Given this list of marker genes LMOD2, KHDC3L, DIAPH1, MIR21, SYNPO2L, ACTR3, MYO1F, TJP1, MICAL1, CCR7, CAPZA2, TMSB15A (NCBI Gene Id 11013), DIAPH2, C15orf62, PACSIN1 (protein kinase C and casein kinase substrate in neurons 1), ARAP1, SYNPO2, TSC1, CORO6, TACR1, FAT1 (FAT atypical cadherin 1), HIP1, ARPIN, JAK2, TMOD3, RAC1, ADD1, CDC42EP2, WIPF3, GSN, SPIRE1, RICTOR, TAGLN3, VASP, SH3D21, PHACTR1 (NCBI Gene Id 81705), CTTN, MYO7B, PALM2AKAP2, RND3, RHOA, DNM2, SPTBN2, SMAD3, CNN3, MICALL2, SHROOM4, TRPV4, KASH5, KBTBD13, WASHC3, FSCN1, S1PR1, HSP90B1, GAS2L2, ITGB1, PFN3, MYO7A, MYO5C, WASHC5, DBN1, TMSB10 (NCBI Gene Id 9168), ERMN, SYNPO, SPIRE2, RHPN2, SLC9A1, WASF2, CORO2B, ARRB1, ARHGEF10, MICAL3, SDC4, MYOC, ARPC1B, GHSR, INF2, MYO5B, MTSS1, WASHC4, PLS3, FCHSD1, TLE6, ENAH, NRAP, ARHGAP6, KANK2, CORO7, SPTBN5, RHPN1, POF1B, WASL, ARF6, LIMA1, PAK2 (p21 (RAC1) activated kinase 2), CFL1, CX3CL1, SORBS3, ITGB1BP1, IQGAP2, PPP1R9B, CYRIB, XIRP1, PROX1, BCAR1, PTK2B, ALOX15, GMFG, PRKCI, TESK1, CORO1A, CORO1B, ARHGEF10L, PXN, CAPG, PPM1E, MTPN, RAC2, SFRP1, BBS4, RAC3, CCN2, ASAP3, MYADM, MARCKSL1, ARPC3, RND2, SH3BP1, WASH3P, EPHA1 (EPH receptor A1), APOA1, MYO1G, GPR65, ROCK2, WNT4, VIL1, MYO15A, SHROOM2, SRF, RHOF, TMSB15B, NCKAP1L, PTGER4, GAS2, FHOD1, ADD2, NEDD9, DIAPH3, TMOD2, MYO1E, PIK3R1 (NCBI Gene Id 5295), MARCKS, CORO1C, ARHGEF2, FSCN3, TTC8, XIRP2, AIF1L, SORBS1, ARF1, TTN, CRYAA, PRKN, RHOBTB1, ESPN, SAMD14, HDAC6, CYFIP2, RNH1, ARFIP2, PPM1F, CARMIL1, AQP5-AS1, CCL11, CDC42EP5, NEB, CYRIA, CNN2, CAPZB, WASH6P, RGS4, PIK3CA, CSF3, C9orf72, OAZ3, DSG3 (desmoglein 3), ACTN2, TPM3, DPYSL3, GMFB, CLASP2, KPTN, CTNNA2, ELMO3, SSH3, INPPL1, DLG1, RHOC, CRACD, CATIP, ESPNL, RASA1, PYCARD, TCAP, S100A10, RFLNB, PDLIM3, SLIT2, OOEP, MTOR, SNX9, ARHGAP25, ELMO2, SSH1, SPTB, MAD2L2, SHROOM1, NPHS1, PDXP, PDLIM1, GAS2L3 (growth arrest specific 2 like 3), TAC1, ASB2, WASHC1, NAA80, NCK2, DSTN, PLEK, CAP1, F11R, AMOT, CLRN1, SPECC1L, SPTBN4, MYO1B, ARHGAP18, DNAI3, TRIOBP, MICAL2, ESAM, SCIN, PFN2, CXCL12, ACTG1, TPM4, CCL26, TAGLN2, RAPGEF3, SPTBN1, LATS1 (large tumor suppressor kinase 1), ZYX, RHOV, ZBED3, FER, ELN, SPTA1, BLOC1S6, LIMCH1, MYO5A, SH3KBP1, PHLDB2, FHDC1, MIR138-1, NCK1 (NCBI Gene Id 4690), LCP1, LMOD1, TWF1, CAP2, EPS8, SRC, EZR, EMP2, CLASP1, PAWR (pro-apoptotic WT1 regulator), DAAM2, LIMK1, ROCK1, LIMD2, MSRB1, AP1AR, FMN1, KCTD13 (potassium channel tetramerization domain containing 13), PLS1, ARHGEF18, WDR1, SWAP70, RHOBTB2, SSH2, ARPC2, FLNA, DMTN, FSCN2, CCL21, RHOU (NCBI Gene Id 58480), ABL1, ARPC5 (actin related protein 2/3 complex subunit 5), MYO19, ELMO1, TMOD4, SPATC1L, CCL24, RHOH, TPM1, HAX1, ARPC1A, MET, HCK, ADD3, AIF1, KANK4, TMOD1, RHOG (ras homolog family member G), ANG, RGCC, GHRL, ARPC5L, PAK3, WASHC2A, BRAF, RHOJ, MSRB2, NLRP5, LUZP1, ACTR2, CNN1, WHAMM, AVIL, WASF1, TGFB3, SVIL, NF2, SHANK1, CYFIP1, ZEB2 (zinc finger E-box binding homeobox 2), CDC42, TWF2, VILL, CDC42EP1, GAS2L1, PRKCD, IQGAP1, ARHGAP40, ALDOA, MYL9, BIN3, FRMD7, SERPINF2 (NCBI Gene Id 5345), BAIAP2L1, FMN2, TPM2, TRIM27, PFN1, HIP1R, CD47, INPP5K, COBL, ARHGAP35 (Rho GTPase activating protein 35), SEMA5A, MKKS, SHTN1, CD2AP, ITGB5, PIK3R2, TRPV3, ACTA1, BRK1, ACTN1, CFL2, ABITRAM, GRB2, AQP2, ALMS1, EVL, MYO1C, PREX1, CAPZA3, FCHSD2, RND1 (Rho family GTPase 1), TMSB15C, KANK1, BAG4, SHROOM3, TNFAIP1, PAK1, MIR214, TMEFF2, ARHGAP28, IQGAP3, ARHGAP12, SPTAN1, PPP1R9A, LMOD3, MYO1A, WASHC2C, CARMIL2, RHOQ, SHANK3, TMSB4Y, WIPF1, BIN1, WASF3, CCDC88A (NCBI Gene Id 731560), RFLNA, BAIAP2L2, USH1C, RHOD, FERMT2, CGNL1, COTL1, PPFIA1, CAPZA1, MYO1D, NRP1, MYO6, PLEKHG2 (NCBI Gene Id 64857), MIR149, F2RL1, CDC42EP3, ABI2, ARFGEF1, TENM1, PLEKHH2, FLII, RHPN2P1, FAM171A1, ABI1, PICK1, MYO1H, KIRREL1, TTC17, NCKAP1, CARMIL3, WAS, BAIAP2, TGFBR1, PRKCE, RDX, ARPC4, DLC1, BCL2, MAGEL2, MLST8, CALD1, TMSB4X, KANK3, NEBL (NCBI Gene Id 51739), PLEC, TACSTD2, HCLS1, CDC42EP4, RHOB (NCBI Gene Id 388), GBA2, RUFY3, GDPD2, STMN1, CAV3, CUL3 (NCBI Gene Id 8452), ARHGEF5, PDCD10, LPAR1, ACTC1, PLA2G1B, MIR20A, FAM107A, ARHGEF15, ARFIP1, JMY, here is a description of the gene set: Human Gene Set: GOBP_ACTIN_FILAMENT_ORGANIZATION A process that is carried out at the cellular level which results in the assembly, arrangement of constituent parts, or disassembly of cytoskeletal structures comprising actin filaments. Includes processes that control the spatial distribution of actin filaments, such as organizing filaments into meshworks, bundles, or other structures, as by cross-linking. studied in species Homo sapiens